The following is a description of a gene set: Mouse Gene Set: WP_OXYLIPINS_PATHWAYS Oxylipins pathways species: Mus musculus, and this is the list of marker genes: Ltc4s, Fads2, Fads1, Hpgd, Ptgs2, Dpep1, Tbxas1, Ggt1, Alox12, Lta4h, Alox5, Hpgds, Alox15, Ptges, Gpx1, Cbr1, Prxl2b, Ephx2, Ptgds, Alox8